Given this list of marker genes Has2, Hyal2, Aqp1, Aqp4, Inpp5k, Aqp2, Aqp6, Ctns, Aqp7, Sctr, Aqp3, Mllt6, here is a description of the gene set: Mouse Gene Set: GOBP_RENAL_WATER_TRANSPORT species: Mus musculus The directed movement of water (H2O) by the renal system.